Given this list of marker genes NLRP7, IKBKB, EZH2, IL17F, TLR4, ABCD2, NFKBIA (NCBI Gene Id 4792), PER1, NOD2, MIR324, PLA2G3, EXTL3, TLR6 (NCBI Gene Id 10333), MIR146A, SPINK7, IL17B, IL17D, HIF1A (hypoxia inducible factor 1 subunit alpha), APPL1, MIR98, STAT3, MIR125A, CUEDC2, MIR17, TLR3 (NCBI Gene Id 7098), TNF, CHRNA7, PSG9, F2, MIR16-1, BAP1, CD6, MIR136, MIR338, JAK2, ZFP36, IL17A, RELA, IL17RA, PLA2G10, ZC3H12A, IL1R2, NOS2, MIR140, MIR26A1, MIR221, PLD4, IL17RC, NFKB1, TREM2, MAPK14, EPHB2, HMOX1, PLD3, MACIR, MEFV, MIR93, PRKCA, PYCARD, SIRPA, MAPK9, ADCY7, ALOX5, MIR197, MIR129-1, CARD9, APOD, CLEC7A, APPL2, KPNA6, MIR378A, IRF3, IL6, MIR21, MIR203A, PPARA, LEP, MYD88, GBP5 (guanylate binding protein 5), MIR222, NLRC3, ABCD1, CHID1, LILRB4, MIR135A1, MIR675, TICAM1, PDCD4, GPSM3, here is a description of the gene set: species: Homo sapiens The synthesis or release of a cytokine following a inflammatory stimulus as part of an inflammatory response, resulting in an increase in its intracellular or extracellular levels. Human Gene Set: GOBP_CYTOKINE_PRODUCTION_INVOLVED_IN_INFLAMMATORY_RESPONSE